The following is a description of a gene set: species: Homo sapiens Both Ki-ras mutation and hepatocyte growth factor (HGF) receptor Met overexpression occur at high frequency in colon cancer. This study investigates the transcriptional changes induced by Ki-ras oncogene and HGF/Met signaling activation in colon cancer cell lines in vitro and in vivo. The model system used in these studies included the DLD-1 colon cancer cell line with a mutated Ki-ras allele, and the DKO-4 cell line generated from DLD-1, with its mutant Ki-ras allele inactivated by targeted disruption. These cell lines were transduced with cDNAs of full-length Met receptor. Microarray transcriptional profiling was conducted on cell lines stimulated with HGF, as well as on tumor xenograft tissues. Overlapping genes between in vitro and in vivo microarray data sets were selected as a subset of HGF/Met and Ki-ras oncogene-regulated targets. Using the Online Predicted Human Interaction Database, novel HGF/Met and Ki-ras regulated proteins with putative functional linkage were identified. Novel proteins identified included histone acetyltransferase 1, phosphoribosyl pyrophosphate synthetase 2, chaperonin containing TCP1, subunit 8, CSE1 chromosome segregation 1-like (yeast)/cellular apoptosis susceptibility (mammals), CCR4-NOT transcription complex, subunit 8, and cyclin H. Transcript levels for these Met-signaling targets were correlated with Met expression levels, and were significantly elevated in both primary and metastatic human colorectal cancer samples compared to normal colorectal mucosa. These genes represent novel Met and/or Ki-ras transcriptionally coregulated genes with a high degree of validation in human colorectal cancers. Human Gene Set: SEIDEN_ONCOGENESIS_BY_MET from publication Seiden-Long IM, Brown KR, Shih W, Wigle DA, Radulovich N, Jurisica I, Tsao MS (PMID 16158056) Genes changed in xenograft tumors formed by DLD-1 or DKO-4 cells (colon cancer) overexpressing MET., and this is the list of marker genes: PAPOLA, HAT1, TCEA1 (transcription elongation factor A1), NSA2, EIF5, YME1L1, GNAI3, F2RL1, P4HA1, ACTR3, PLOD2, SCP2, NPM1 (NCBI Gene Id 4869), RTCA, SH3BGRL, SPTLC1, RIOK3, PLS3, HNRNPH2, MBIP, HSP90AA1, SERBP1, SERINC1, TASOR2, RSL24D1, CSDE1, SELENOF, SMN1, SLC25A24, SEC23A, C6orf62, STK26 (NCBI Gene Id 51765), CCT6A, EEF1A2, TAF1D, TMX1 (thioredoxin related transmembrane protein 1), MMADHC, IFITM1, CD46, AASDHPPT, GLS, PDE8A, ARHGEF12, EREG (epiregulin), CLIC4, LAMB1, TCERG1 (NCBI Gene Id 10915), EPS8, TMEM123, COMMD3, HSPA4, LYPLA1, ANXA4, NCKAP1, PCMT1, SUB1, NIPSNAP2, PNRC2, ZBED5, HIGD1A, HNRNPA3, SLC38A2, MBNL1, GRSF1, ITGA6, PTEN, UBA2, UGDH, SLC39A6, TSPAN8, SERP1, IPO7, ANXA3, SRP72, IFNGR1, TRAM1, ATP2A1, ADAM9, CAPZA1, AIDA, MSMO1, STAT1, DPM1, COMMD8, CERS6, CXCL5, RRM1, CDK1, PPP1CB